The following is a description of a gene set: studied in species Homo sapiens Genes down-regulated in metastatic vs non-metastatic stromal cells originated from either bone or prostate tissues. Human Gene Set: SUNG_METASTASIS_STROMA_DN from publication Sung SY, Hsieh CL, Law A, Zhau HE, Pathak S, Multani AS, Lim S, Coleman IM, Wu LC, Figg WD, Dahut WL, Nelson P, Lee JK, Amin MB, Lyles R, Johnstone PA, Marshall FF, Chung LW (PMID 19047182) Human bone stromal cells, after three-dimensional coculture with human prostate cancer (PCa) cells in vitro, underwent permanent cytogenetic and gene expression changes with reactive oxygen species serving as mediators. The evolved stromal cells are highly inductive of human PCa growth in mice, and expressed increased levels of extracellular matrix (versican and tenascin) and chemokine (BDFN, CCL5, CXCL5, and CXCL16) genes. These genes were validated in clinical tissue and/or serum specimens and could be the predictors for invasive and bone metastatic PCa. These results, combined with our previous observations, support the concept of permanent genetic and behavioral changes of PCa epithelial cells after being either cocultured with prostate or bone stromal cells as three-dimensional prostate organoids or grown as tumor xenografts in mice. These observations collectively suggest coevolution of cancer and stromal cells occurred under three-dimensional growth condition, which ultimately accelerates cancer growth and metastasis., and this is the list of marker genes: CDCA5, PARP4, ACP5, KLHL30 (NCBI Gene Id 377007), MT1B, KIFC3, HELLS, ZNF367 (zinc finger protein 367), LTBP2, ARF6, SCRN1, HIPK2, CDC45, NOP56, MT1X, HNRNPF, MCM6, EML1, GMNN, PKMYT1, EGFR, MT1F, POLE2, PITPNC1, MCM5, LGALS2, UBR7, MT1G, VPS50, PCNA, IL13RA2, NUP153, DERA, MMP3, MCMBP, SERPINE1, MCM3, DTYMK, DHRS7, ACKR3, PNP, E2F1, NPC2, HCP5, MT1E, PARP2, CENPU, LYAR, NOLC1, G3BP2, MT1H, NCAPG2, BYSL, DEK